The following is a description of a gene set: species: Homo sapiens part of: Apoptotic cleavage of cellular proteins Reactome Pathway: Caspase-mediated cleavage of cytoskeletal proteins Caspase-mediated cleavage of a number of proteins in the cortical actin network  microfilament system and others involved in maintenance of the cytoskeletal architecture (vimentin, or Gas2 and plectin) may directly contribute to apoptotic changes in cell shape., and this is the list of marker genes: GSN, PLEC, ADD1, CASP7, CASP8, DBNL, SPTAN1, VIM, CASP6, GAS2, CASP3, MAPT